The following is a description of a gene set: Mouse Gene Set: GOBP_REGULATION_OF_CYTOPLASMIC_TRANSLATIONAL_INITIATION Any process that modulates the frequency, rate or extent of cytoplasmic translational initiation. studied in species Mus musculus, and this is the list of marker genes: Impact, Eif2ak4 (NCBI Gene Id 27103), Rpl13a, Nck1, Ythdf2, Sh3bgrl, Pkp1, Akt2, Mettl3